Given this list of marker genes Amotl2, Fem1c, Frmd4a (NCBI Gene Id 99027), Dock4, Fbxo27, Peds1, Fam110b, Casp2, Chpf2, Nmnat2, Nr1d2, Nudt13, Cfi (complement component factor i), Slc27a4 (NCBI Gene Id 99453), Eif3j1, Synpo2, Fer, Ano7, Antxr2, Daam1, Apcs, Ncor1, C1qtnf4, Zfp689, Map7d1, Atf1, Map4k2, Mphosph9 (M-phase phosphoprotein 9), Eif3j2, Atrx, Prr3, Slc44a2, Foxj3, Papola, Reck, Yes1, Taf4b, Plcxd2, Fam167a, Sh3glb1, Tmcc3, Hoxa9, Zfp148, Ptk7, Jmjd1c, Pik3r3, P2ry2, Rad9a, Gpsm1, Has2, Diaph2, B3gnt2, Phf6, Dixdc1, Foxp2, Fsbp, Kit, Pde4b, Cnst, Trip13, Fabp3, Tmem64, Kif5a, Lpcat3, Rabgap1, Ubxn7, Ppp1r12a (NCBI Gene Id 71736), Nectin1, Stum, Ncapg, Rgs8, Tnrc6a, Extl3, Phldb1, Ube2n, Stag1, Tmem229a, Txk, Add3 (NCBI Gene Id 98171), Polr2c, Elk1, Rad54b, Tnrc6b, D630039A03Rik, Ilrun, Fyco1, Sinhcaf, Net1, Atoh1, Pip4k2b, Pdgfra, Phip, Camsap2, Hsd17b13, Srgap2, Onecut2, Clic5, Gpr22, Pcsk6, St6galnac3, Hook3, Satb2, Olfm1, Astn1, Cfl1, Reps2, Gpr3 (NCBI Gene Id 14748), Sort1, Agl, Tspan4, Tapt1, Stxbp5l, Il18r1, Gcc1, Topors, Acat1, Aagab, Tbl1xr1, Plod3, Anks1, Mfap3l, Mcm7, Uchl4, Scyl3, Cacna2d1, Pcca, Ppp2r3a (protein phosphatase 2, regulatory subunit B'', alpha), Lamp2, Mpig6b, Slc22a23, Prkci, Hectd2, Mmp24, Zer1 (NCBI Gene Id 227693), Asic2, Acsm3, Paip1, Zdhhc15, Vps72, Mmd, Hras, Rnf185, Cers2, Usp48, Chp1, Eid2b, Pja2, Nuak1, Ythdf2, Nfat5, Ankub1, Itpr1, Taf12, Kdm2a, Sptbn1, Fam149b (family with sequence similarity 149, member B), Vsig4, here is a description of the gene set: from publication Chen Y, Wang X (PMID 31504780) Genes predicted to be targets of miRBase v22 microRNA mmu_miR_5134_5p in miRDB v6.0 with MirTarget v4 prediction scores > 80 (high confidence targets). species: Mus musculus Mouse Gene Set: MIR_5134_5P